The following is a description of a gene set: species: Mus musculus Mouse Gene Set: GOMF_PHOSPHOLIPASE_ACTIVITY Catalysis of the hydrolysis of a glycerophospholipid., and this is the list of marker genes: Stx4a (syntaxin 4A (placental)), Abhd4, Plcb4, Pla2g4e, Plaat5, Pgap6, Arf1, Apoc2, Pla2g2e, Pnpla7, Plaa, Pla2g4c, Proca1, Liph, Napepld, Pla2g3, Alkbh5, Gdpd3, Arl1, Smpd4, Fyn, Gdpd5, Pnpla8, Pnpla6, Lipg, Casp3, Plcb1, Pld4, Plch1, Ccl3, Plcz1, Abhd16b, Pla2g15, Apoc2l (apolipoprotein C2 like), Anxa2, Lipc, Nsmaf, Ccl5, Gdpd1, Pnpla3, Pla2g2d, Pla2g12a, Plb1, Plcl2, Plcg1, Arf4, Angptl3, Pla2g4a, Anxa1, Plaat1, Smpd5, Pla2g5, Btk, Smpd1, Pnliprp2, Smpd2, Pld3, Lypla2, Oc90, Plcb3, Smpd3, Eed, Pla2g7, Plbd2, Pla2g10, Aspg, Smpdl3b, Pla2g2a, Abhd12, Hmox1, Gm2a, Plbd1, Plce1, Cel, Prdx6, Scgb1a1, Ddhd2, Plcd4 (NCBI Gene Id 75716), Enpp7, Plaat3, Pinlyp, Pla2g4b, Pld6, Pla2g4f, Pld2, Lipi, Pla2g4d, Lpl, Smpdl3a, Lcat, Lypla1, Plch2, Plcg2, Abhd12b, Pnpla2, Ccl8, Src, Abhd16a, Abhd3, Pnlip, Arhgap6, Apoc1, Pdgfra, Plcl1, Pla2g2f, Enpp2, Ddhd1, Plcd3, Pla2g12b, Pdpk1, Pla1a, Sec23ip, Pnliprp1 (NCBI Gene Id 18946), Pla2g6, Prdx6b, Ccr1, Anxa3, Gde1, Plcb2, Lck, Pitpnm3, Hras, Pla2g2c (phospholipase A2, group IIC), Plcd1, Pld1, Ccr1l1, Ppt1, Abhd6, Gpld1, Pla2g1b